Given this list of marker genes Mttp, Cpt2 (NCBI Gene Id 12896), Acads, Acadvl, Hadh, Cpt1a, Acadm, Acaa2, Slc25a29, Echs1, here is a description of the gene set: Mouse Gene Set: WP_FATTY_ACID_OXIDATION Fatty acid oxidation species: Mus musculus